The following is a description of a gene set: The development of an oncogenic state is a complex process involving the accumulation of multiple independent mutations that lead to deregulation of cell signalling pathways central to the control of cell growth and cell fate. The ability to define cancer subtypes, recurrence of disease and response to specific therapies using DNA microarray-based gene expression signatures has been demonstrated in multiple studies. Various studies have also demonstrated the potential for using gene expression profiles for the analysis of oncogenic pathways. Here we show that gene expression signatures can be identified that reflect the activation status of several oncogenic pathways. When evaluated in several large collections of human cancers, these gene expression signatures identify patterns of pathway deregulation in tumours and clinically relevant associations with disease outcomes. Combining signature-based predictions across several pathways identifies coordinated patterns of pathway deregulation that distinguish between specific cancers and tumour subtypes. Clustering tumours based on pathway signatures further defines prognosis in respective patient subsets, demonstrating that patterns of oncogenic pathway deregulation underlie the development of the oncogenic phenotype and reflect the biology and outcome of specific cancers. Predictions of pathway deregulation in cancer cell lines are also shown to predict the sensitivity to therapeutic agents that target components of the pathway. Linking pathway deregulation with sensitivity to therapeutics that target components of the pathway provides an opportunity to make use of these oncogenic pathway signatures to guide the use of targeted therapeutics. Human Gene Set: BILD_SRC_ONCOGENIC_SIGNATURE from publication Bild AH, Yao G, Chang JT, Wang Q, Potti A, Chasse D, Joshi MB, Harpole D, Lancaster JM, Berchuck A, Olson JA Jr, Marks JR, Dressman HK, West M, Nevins JR (PMID 16273092) Genes selected in supervised analyses to discriminate cells expressing c-Src (CSK) from control cells expressing GFP. studied in species Homo sapiens, and this is the list of marker genes: SORL1, RAG1, ASH1L, CSTF3, LRP8, TMCC1, HEG1, SECISBP2, ZNF12, SERPINB2, INO80C, LIPG, LSS, PTHLH, GAS2L1, CSNK1A1, YTHDC2, FRMD4B, KDM4B, PROM2, ORC2, ACLY, TRRAP, TSPYL4, ITGAV, VPS13B, EBLN3P, EXTL2, SACS, SLC5A3, CASP1, ASAP2, COL1A1, SLC12A2, MMAB, RRM2, ITPRID2, TNFAIP3, SRC, CA12, LNPEP (leucyl and cystinyl aminopeptidase), IL17RA, TRIM33, HSPH1, DHRS1, TIA1, MARCHF6, ABCC10, COL8A2, ZBTB11, MARK3, DCBLD2, ARIH1, PPP1R15A, FERMT1, EHMT1, DMTF1 (NCBI Gene Id 9988), PRICKLE1